The following is a description of a gene set: Pathway Definition from KEGG: EGF -> (ERBB2+EGFR) -> GRB2 -> SOS -> RAS -> RAF -> MEK -> ERK EGF-ERBB2-RAS-ERK signaling pathway. Pathway ID: N00021. Pathway type: Reference. Pathway class: nt06261 Gastric cancer. Human Gene Set: KEGG_MEDICUS_REFERENCE_EGF_ERBB2_RAS_ERK_SIGNALING_PATHWAY studied in species Homo sapiens, and this is the list of marker genes: KRAS, MAP2K2, HRAS, SOS2, RAF1, ERBB2, MAPK1, MAPK3, EGF, ARAF, SOS1, EGFR, GRB2, BRAF, NRAS, MAP2K1